The following is a description of a gene set: To define the ECM composition of tissues and tumors, we have empolyed a proteomics-based method to enrich and identify ECM proteins and coupled it with a bioinformatic annotation of the matrisome defined as the ensemble of ECM and ECM-associated proteins. To identify ECM proteins important for breast cancer progression and metastasis formation, we used a xenograft model where human breast cancer cells of differing metastatic potenital were orthotopically injected into the mouse mammary fat pad. The poorly metastatic MDA-MB-231 cell line was established from cells isolated from a sample from a triple-negative breast cancer patient. The highly metastatic MDA-MB-231-LM2 line (denoted LM2), was previously selected and characterized for increased metastatic potential to the lungs. 6.5 weeks post-injection, the primary tumors were harvested, ECM proteins were enriched from tumors, and the composition of the ECM-enriched fractions obtained was characterized by mass spectrometry. We define the matrisome of a tumor as the ensemble of proteins detected in two independent biological replicates and by at least two peptides in one of the two replicates. Using this proteomics approach we show that both the tumor cells and the stromal cells contribute in characteristic ways to the production of the tumor ECM. Moreover, we show that both tumor- and stroma-derived proteins differ between tumors of different metastatic potential. Comparison of the matrisomes of MDA-MB-231 tumors and LM2 tumors identifies ECM proteins characteristic of poorly and highly metastatic tumors. This gene set lists the matrisome proteins secreted by the tumor cells and stromal cells in LM2 tumors and not from MDA-MB-231 tumors. Matrisome proteins exclusively detected in highly metastatic breast cancer human-to-mouse xenografts (MDA-MB-231_LM2) in comparison to poorly metastatic breast cancer human-to-mouse xenografts (MDA-MB-231). Human Gene Set: NABA_MATRISOME_HIGHLY_METASTATIC_BREAST_CANCER from publication Naba A, Clauser KR, Lamar JM, Carr SA, Hynes RO (PMID 24618895) studied in species Homo sapiens, and this is the list of marker genes: PLXNB2, ADAM9, F10, PAPLN, EFEMP2, IGFBP4, HCFC2, CCN2, SERPINF1, PRG4, P4HTM, SERPINE2, SERPINC1, COL4A6, COL22A1, CTSB, P3H3, F13B, SNED1, LTBP3, S100A2, CTSF, ADAM10, ANGPTL4, TINAGL1, MFGE8, VWF, EGLN1 (egl-9 family hypoxia inducible factor 1), AGRN, C1QA, HABP2, SRPX, C1QC, S100A10, CTSC, TIMP1, COL24A1, LOXL2, ITIH4, HTRA1, CST3